Given this list of marker genes Mcee, here is a description of the gene set: electronically inferred by orthology from the curated human pathway part of: Mitochondrial Fatty Acid Beta-Oxidation Reactome Pathway: Propionyl-CoA catabolism species: Mus musculus This event has been computationally inferred from an event that has been demonstrated in another species.<p>The inference is based on the homology mapping from PANTHER. Briefly, reactions for which all involved PhysicalEntities (in input, output and catalyst) have a mapped orthologue/paralogue (for complexes at least 75% of components must have a mapping) are inferred to the other species.